The following is a description of a gene set: electronically inferred by orthology from the curated human pathway part of: Depyrimidination This event has been computationally inferred from an event that has been demonstrated in another species.<p>The inference is based on the homology mapping from PANTHER. Briefly, reactions for which all involved PhysicalEntities (in input, output and catalyst) have a mapped orthologue/paralogue (for complexes at least 75% of components must have a mapping) are inferred to the other species. studied in species Mus musculus Reactome Pathway: Cleavage of the damaged pyrimidine, and this is the list of marker genes: Neil1, Mbd4, Ogg1, Neil2, Nthl1, Tdg